The following is a description of a gene set: Human Gene Set: GOCC_MKS_COMPLEX studied in species Homo sapiens A protein complex that is located at the ciliary transition zone and consists of several proteins some of which are membrane bound. Acts as an organiser of transition zone inner structure, specifically the Y-shaped links, in conjunction with the NPHP complex. The MKS complex also acts as part of the selective barrier that prevents diffusion of proteins between the ciliary cytoplasm and cellular cytoplasm as well as between the ciliary membrane and plasma membrane., and this is the list of marker genes: TMEM107, TCTN1, AHI1, B9D1, TMEM216, B9D2, TCTN2, TMEM67, MKS1, CC2D2A, TMEM17, TMEM231, CEP290